Given this list of marker genes APTX, SLC31A1, PHF11, NOL8, CDC73, MED6, STAT2, RSAD2, SERPINB8, TENT5A, LAX1, AARSD1 (NCBI Gene Id 80755), SFSWAP, FBXO28, IFIT3, GPN3, IFITM1, ADAR, GLS, DDX60, SAMD9, STAP1, AGA, SNAPC1, VCPIP1, DROSHA, MIS12, NCOA3, PIGK, SLC25A32, IFIT2, MAIP1, NADK, TMEM33, BPNT2, IFIT1, PCID2, TGDS, IRF8, NIPAL3, ARFGEF2, UTP14C, IFI27, SLC39A14, B3GNT2, IFIT5, ISG20L2, TMED5, MGA, UVRAG, ZCCHC2, DCTN4, DDX10, CD69, TIMM17A, C1GALT1, MAK16, PALS2, IFRD1, MX2, SNX2, CD48, LARP1, APOL6, EIF2AK2, RBM28, MTF2, PPP2R2A, SAR1B, INTS12, CHMP5, IFIH1, FER, HERC6, DCP1A, TOP1, TMEM9B, MRS2, PAQR3, SP110, ZCCHC10, PRRC1, BZW2, TDRD7, IFI44L, PALB2, POLR3G, ARFIP1, NCAM2, TRIM25, UBC, CD38, BMP8B, PARP12, SRR, ZNHIT6, IFI35, LAP3, WDR47, EMC2, POLR3F, ARMC8, ARHGAP5, SP100, RBM22, IFITM2 (NCBI Gene Id 10581), USP18, DOP1A, KRTAP1-1, RNF146, CRK, EIF4A1, EHD4, DENND1B, COQ10B, N4BP1, IFI44, IL10, ZZZ3, LIAS, HERC5, IRF9 (NCBI Gene Id 10379), SLC24A1, ISG20, ISG15, RBM7, PLSCR1, PNO1, SLC39A9, CREM, XAF1, TRIM21, HOMER1, TBPL1, ENPP2 (ectonucleotide pyrophosphatase/phosphodiesterase 2), OAS1, SETD4, CLEC2D, OASL, IDH3A, TDRD3, XRCC4, NMI (NCBI Gene Id 9111), SELENOP, AEN, MX1 (MX dynamin like GTPase 1), CMAS, LNPEP, GALNT7, EXOSC2, MGAM, ORC4, RAP1B, TRIM38, SINHCAF, SRD5A1, FERRY3, TRIM22, IBTK, WDR44, IPO8, RIGI, OAS2, RTP4, DHX58, TCP1, SOBP (NCBI Gene Id 654119), KCTD14, RIF1, STAMBP, TADA2A (NCBI Gene Id 96291), DCAF17, VN1R1, RIPK1 (receptor interacting serine/threonine kinase 1), BAG4, IFI6, IRF7, ETV3, EIF5, QKI, GTF2B, NOC3L, LAMP3, DTWD1 (DTW domain containing 1), LRIF1, TRAPPC4, USP16, HERC4, BCAP29, RCL1, TWNK, BST2, OAS3, SP140, ACP1, ELF1, SLC35A5, BCL2L14, SYNJ1, FCHSD2, here is a description of the gene set: The transcriptome of naive OT-I T cells was compared to memory CD8 T cells after 1, 2, 3, or 4 infection with ovalbumin expressing Listeria monocytogenes (LM-OVA). from publication Wirth TC, Xue HH, Rai D, Sabel JT, Bair T, Harty JT, Badovinac VP (PMID 20619696) species: Homo sapiens Human Gene Set: GSE21360_NAIVE_VS_QUATERNARY_MEMORY_CD8_TCELL_UP Genes up-regulated inCD8 T cells: naïve versus 4' memory.